Given this list of marker genes SERPINE1, BLOC1S6, FGA, CD9, PDIA2, SLC4A5, APLNR, C1QTNF1, ADAMTS18, AQP1, F11R, SRC, MTX1, APLN, SH2B3, PROC, CSN2, P2RY1, F7, EMILIN1, GGCX, PRKACB, DGKA, HGFAC, F2RL1, GPAT4, DGKZ, GHRHR, IL6, F8, CREB1 (NCBI Gene Id 1385), HK2, ADAMTS13, MYO5B, GP1BB, NCOA1, SCUBE1, PEAR1, CELSR2, PROS1, RAB27A, DCANP1, F3, NPR1, F10, PLG, HPSE, DDR1, OPRK1, FIBP, F12 (NCBI Gene Id 58992), HIF1A, SERPINA1, CYP4A11, ILK, TPH1, ANXA2, ENTPD1, BTC, HSD11B2, GNAS, ENTPD2, F9, DGKB, GNAI2, PRKCD, NFE2, TP73, PDGFRA, AVPR2, STATH, EPHB2, AXL, CAD, IL6R, CSRP1, GATA1, TLR4, CORO2B, CYP4F2 (NCBI Gene Id 8529), ATG5, NEURL1, SLC6A4, SELP, CFTR, ATP6V1B1, SOCS2, ENPP4, DGKD, METAP1, DTNBP1, ITGB3, AKAP11, WAS, SERPINC1, NKX2-3, COL3A1, ST3GAL4, ADRA2C, PRRG2, SHH, MYH9, SERPIND1, ANXA5, AP3B1, PLEK, TMX1, GNAQ, MUC2, PLAU, VAMP8, CEL, PLAT, PRRG1, MPIG6B, BLOC1S4, VTN, NOS3, HYAL2, PLSCR1, MLLT6, SERPINB2, ACTN1, MED1, PDSS2, GUCA2B, KCNN4, F2R (coagulation factor II thrombin receptor), SCNN1B, RAP2B (NCBI Gene Id 5912), ANO1, CLIC1, PRL, DGKK, DGKI, TLN1, PPP3CA, ADGRG1, EMP2 (NCBI Gene Id 2013), THBD, TSPAN9, MTCO2P12, HNF4A, NR1H3, SCNN1G, GJA5 (NCBI Gene Id 2702), STAT5A, PRKACA, TSPAN18, ANGPTL6, MMRN1, FGF10, HRG, C1GALT1C1, PRKACG, TSPAN8, AGR2 (NCBI Gene Id 10551), NEUROG1, SLC6A3, DGKG, KRT1, KLKB1, FUNDC2, STAT5B, CPB2, FLNA, ZBTB7B, GUCA1B, GP5, COMP, CYP4F12, PRKCE, STXBP3, DRD2, ADM, VKORC1, UMOD, F11 (coagulation factor XI), SVEP1, DGKQ, SERPINF2, ACTG1, WFS1, ADRA2B, FCER1G, SLC7A11, COPA, INPP5K, HTR4, ANGPTL2 (NCBI Gene Id 23452), EXT2, MYL9, JMJD1C, WNK1, PDIA3, MERTK, EDN1 (NCBI Gene Id 1906), AQP3, PROZ, AQP2, UBASH3B, ITPK1, PLAUR, SLC29A1, F2, CSN3, PDGFB, CDO1, CEACAM1, ABCB1 (ATP binding cassette subfamily B member 1), SERPINA10 (NCBI Gene Id 51156), P2RX1, FZD6, PRDX2, ADRA2A, LYN, UPRT, SRF, HAS2, THBS1, PIK3CG, PABPC4, FLI1, GPI, NR1H2, PIK3CB, CYBA, PROCR, MYL12A, PTPN6, NME1, WNK3, PRSS56, TRPV4, ANXA8, BPIFA1, WNT3A, FBLN1, ANGPTL4, ADORA2A, HTR2A, PIK3CA, PAFAH2 (NCBI Gene Id 5051), OAS2, ITPR3 (inositol 1,4,5-trisphosphate receptor type 3), NEGR1, APOH, ATP7B (ATPase copper transporting beta), XBP1, LCK, ALOX12B, HEG1, VAV2, EMILIN2, CHRM1, NFE2L2, DGKH, TSPAN32, HSPB1, PRKG1, USF1, TBXA2R, NLRP6, HPS4, F13A1, CD36, IL6ST, MFSD2B, TYRO3, GP9, TTR, AKR1B1, ANO6, EDNRB, RASA3, ADA, HPS6, ITGA2, NPR3, CHRM3, MAPK14, ACTB, SERPINE2, USF2, VAV1, JAK2, C4BPB (complement component 4 binding protein beta), STXBP1, FGG, CCND1, AVP, OXTR, FGL1, TIFAB, AK3, ALOX12, GP6, TFPI, ANGPT2, VAMP2, KNG1, TEC, TREML1, VPS33B, SAA1, MT-CO2, TFPI2, AQP6, VWF, ADORA1, ADCY6, CYP4F11, OXT, ANGPT4, CD59 (CD59 molecule (CD59 blood group)), ANGPT1, ANGPTL7, BLOC1S3, NCOR2 (NCBI Gene Id 9612), F5, GNA12, PDPN, VDR, CYP11B2, P2RY2, VIP, LNPK, VEGFA, SCT, PRRG3, F2RL2 (NCBI Gene Id 2151), CELA2A, XDH, EXT1, PRKCA (NCBI Gene Id 5578), SYK, APOE, ANGPTL1, GAS6, PPIA, SLC22A2, SLC4A1, ADTRP, SERPING1 (serpin family G member 1), AQP4, VCL, PDGFA, CD40LG, PTPRJ, TRPV5, PRLR (prolactin receptor), HPS5, FOXB1, FGB, F13B, PF4, TRAF3IP2, FOSL2, CAV1, DGKE, ERBB4, NPPB (NCBI Gene Id 4879), FERMT3 (FERM domain containing kindlin 3), P2RY12, ZNF385A, VAMP3, PRRG4, WNK4, VAV3, FAP, LMAN1, STK39, SCNN1A, GNA13, GP1BA, FOXA2, PTPRO, PRICKLE1, CD40, TUBB1, CTSG, AQP5, HBB, PLCG2, PRKCQ, SLC4A9, LACRT, PLA2G4A, F2RL3, here is a description of the gene set: Human Gene Set: GOBP_REGULATION_OF_BODY_FLUID_LEVELS Any process that modulates the levels of body fluids. species: Homo sapiens